Given this list of marker genes Otud5, Lgals9 (NCBI Gene Id 16859), Ephb2, Ascl2, Loxl3, Mir326, Ep300 (E1A binding protein p300), Opa1 (OPA1, mitochondrial dynamin like GTPase), Clec4n, Lgals1, Malt1 (NCBI Gene Id 240354), Nfkbiz, Clec7a, Rc3h2, Ccr6, Card9, Jak2, Il2, Brd4, Nlrp10, Tbx21, Zbtb7b, Nfkbid, Il23a, Mir301, Foxp3, Ccl20, Tnfsf18, Nlrp3, Prkcq, Tyk2, Pf4, Brd2, Smad7, Rc3h1, Il4, Il27ra, Zc3h12a, Arid5a, Cd69, here is a description of the gene set: Any process that modulates the frequency, rate or extent of T-helper 17 type immune response. Mouse Gene Set: GOBP_REGULATION_OF_T_HELPER_17_TYPE_IMMUNE_RESPONSE species: Mus musculus